Given this list of marker genes Eya2 (EYA transcriptional coactivator and phosphatase 2), Gdpd1 (NCBI Gene Id 66569), Plcb1, Ublcp1, Ephx2, Gdpd2, Ptpro, Dusp22, Epm2a, Plcb4, Pfkfb1, Tab1, Pde4b (phosphodiesterase 4B, cAMP specific), Ppp4c, Smpdl3a, Pde1a, Cpped1, Anp32e, Plcxd3, B3gat3, Dusp9, Ppp2r1b, Ptprh, Tns1, Ppp1r3d, Fbp1, Dusp7, Plppr5 (NCBI Gene Id 75769), Ppm1k, Mtmr3, Ptpn18, Nt5dc3 (NCBI Gene Id 103466), Aptx, Itga1, Pld3, Ptp4a1, Plch1, Ppp1r17, Ptpra, Fra10ac1, Ppp1r1b, Dusp1, Tns3, Mtmr4, Ptpn1, Lpin1, Ppp2r2b, Ptprk, Nt5dc1, Synj1, Mtmr11, Apex1, Elfn1 (NCBI Gene Id 243312), Tescl, Cmya5, Ptprn2, Ppp3r1, Calm1, Ppp3cb, Acp7, Ptpn21, Plcz1, Tdp2, Ppm1l, Nt5c2, Minpp1, Inpp5a, Ppp1r14a, Enpp1, Pde6c, Inpp5e, Phactr3, Dusp12 (dual specificity phosphatase 12), Ppm1h, Mtmr6, Pde6g, Dmpk, Vrk3, Cdkn3, Ppp2r5b, Cdc25b, Arf1, Ssh1, Pfkfb2, Mtmr10, Tulp2, Arpp19, Ptpdc1, G6pc3, Styx-ps, Pde7a, Ptprj, Gdpd4, Pgp, Slc39a10, Plcl2, Plcb3, Ppp1r3c, Dusp6, Enpp3, Tigar, Car3, Ssh3, Mtm1, Gpcpd1, Dusp26 (NCBI Gene Id 66959), Gnas, Dusp18, Cnep1r1, Ptk2 (PTK2 protein tyrosine kinase 2), Igfbp2, Ppp1r27, Pde1c, Nt5c3b, Mtmr14, Ppp2r1a, Psph, Acp1, Dusp16, Ppp4r4, Ppp1r16a, Plppr2, Ppef2, Ptprc, Sbf1, Phospho2, Rcan3 (NCBI Gene Id 53902), Ptprg, Rngtt (RNA guanylyltransferase and 5'-phosphatase), Smpd4, Eya3, Plcl1, Inpp4a (inositol polyphosphate-4-phosphatase, type I), Cip2a, Dusp28, Pald1, Ppm1a, Pip4p2, Ptpn22, Dusp13a, Inpp1, Plce1, Pdgfra, Nt5c1b, Mtmr12, Pon1, Plcd3, Ppp2r5d, Pde10a, Smpdl3b, Nt5dc2, Arf4, Entpd3, Styx, Ppef1, Pde5a, Ptprd, G6pc1, Samhd1, Apex2, Plcd1, Sh3rf2, Ppp1r12b, Pde11a, Ccl5, Phlpp1, Hddc3, Hsp90ab1, Ptpn20, Dusp11, Sgpp1, Ppp1cc, Pld6, Sacm1l, Pudp, Ensa, Ppp1r14d, Alpl, Ctdspl, Ppp1r15a, Napepld, Plch2, Mgat5, Smpd5, Cabin1, Ppp1r3e, Ppp1cb, Acp4, Ppp1r3a, Acp5, Ctdp1, Noct, Sgpp2, Cdc14b, Pptc7, Cnp, Mtmr1, Ppp3ca, Pon3, Pde6b, Lck, Pde2a, Fan1, Ppp4r3c2, Pde3a, Ppp1r15b, Ptprq (NCBI Gene Id 237523), Fbp2, Tpte, Plcg1, Dusp8, Ptpn14, Mppe1, Gnb1, Pde7b, Bod1, Dusp4, Ywhab, Arl1, Plppr3, Ptpn23, Inpp4b, Ywhae, Tprn, Ppp1r1c, Ppp2r3d, Tns2 (tensin 2), Ptpn9, Ppm1f, Ptp4a3, Gnaq, Mtmr7, Ppp1r8, Inppl1, Lhpp, Ppp1ca, Nt5c3, Pld2, Pfkfb4, Tiprl (TIP41, TOR signalling pathway regulator-like (S. cerevisiae)), Dusp21, Pfkfb3, Pank4, Mdp1, Cdca2, Ctdsp2, Tesc, Ppp6c, Nt5c1a, Styxl2, Gde1, Ppp3r2, Dusp10, Ppm1j, Pabir2, Dusp19, Pld4, Prune1 (NCBI Gene Id 77902), Ppp1r1a, Ptprz1, Cry2, Enpp6, Enpp7, Plppr1, Hdhd2, Sirpa, Enoph1, Nt5c, Nt5e, Ppm1g, Ppp4r2, Ppp2r2a, Ppp1ccb, Htt, Impa2, Fig4, Nanp, Ctdsp1, Pip4p1, Ppp2cb, Ptpn3, Tdp1, Plcd4, Ccr1l1, Ambra1, Ppp2r3a (NCBI Gene Id 319351), Igfbp3, Ptpn11, Ppp1r9b, Mtmr2, Rcan2, Ocrl, Rcan1, Hras, Ptpre, Ppa2, Plpp2, Timm50, Alppl2, Ppp6r3, Ppp1r12c, Pgam5, Acp6, Ptpn5 (protein tyrosine phosphatase, non-receptor type 5), Ppp1r26, Nt5m, Plpp1, Ptp4a2, Ssu72, Eya4, Ppp1r14b, Ptprt, Smpd3, Acp2, Ppp4r3c1, Ubash3b, Armt1, Ppp6r1, Smtnl1, Pxylp1, Ptprv, Rpap2, Enpp2, Pde1b, Ppp2r2d, Stx4a, Dnajc6, Ppp1r12a, Ctdspl2, Igbp1b, Pld1, Ppp5c, Ppm1n, Phactr4, Dusp14 (dual specificity phosphatase 14), Csnk2a1, Inpp5k, Ctdnep1, Ppp1r3b, Bpnt2, Ppp2ca, G6pc2, Tmem225, Ppp4r1 (NCBI Gene Id 70351), Ptpmt1, Ppp1r14bl, Nsmaf, Sbf2, Mpped2, Pde4a, Plcxd2, Pde4c, Ptpn6, Ppp1r16b (protein phosphatase 1, regulatory subunit 16B), Inpp5f, Plcg2, Eya1, Ptpru, Cd33, Gtf2f1, Pnkp, Pdp1, Lmtk2, Dusp5, Ppp1r2, Plpp7, Pabir1, Acp3, Ssh2, Phlpp2, Pde8b, Eed, Ptpn7, Ppm1d, Ptpn2, Dusp23, Ptprs (NCBI Gene Id 19280), Dusp2, Pde6h, Dusp3, Ptpn4 (protein tyrosine phosphatase, non-receptor type 4), Bpnt1, Ppp2r5a, Hmox1, Pde4d, Pde6a, 2810408A11Rik, Ppp3cc, Akp3, Ppm1e, Plcb2, Ppp4r3b, Ppp4r3a, Hsp90b1, Gna12, Igbp1, Pde6d, Inpp5b, Bckdk, Phactr1, Ppp2r5e, Pde9a, Ppp1r37, Ptprf, Cdc25a, Ptprb, Atp1a1, Plpp3, Dusp15, Ppp1r10, Ppp2r2c, Ppp1r14c, Pten (NCBI Gene Id 70161), Plpp4, Ptprr, Bmp2k, Gna11, Elfn2, Smpd1, Plcxd1, Pde8a, Ccr1 (NCBI Gene Id 12768), Wbp11, Gpld1, Synj2, Lpin3, Lpin2, Ppp1r35, Phpt1, Plpp6, Gdpd3, Pde3b, Ppp6r2, Ppp2r5c (protein phosphatase 2, regulatory subunit B', gamma), Hddc2, Inpp5j, Ppp1r7, Ptn, Ppp1r11, Nit1, Dusp13b, Impa1 (inositol (myo)-1(or 4)-monophosphatase 1), Bmp2, Ficd, Pp2d1, Pdxp, Ptpn12, Smpd2, Uri1, Gdpd5, Alpi, Ppm1m, Ptpn13, Pdp2, Ppm1b, Adprm, Ptprn, Plppr4, Inpp5d, Dusp29, Plpp5, Ptprm, Styxl1, Phospho1, Myoz1, Ptpa, Ppp1r36, Calm3, Cdc25c (cell division cycle 25C), Ilkap, Cdc14a, Calm2, here is a description of the gene set: Catalysis of the reaction: RPO-R' + H2O = RPOOH + R'H. This reaction is the hydrolysis of any phosphoric ester bond, any ester formed from orthophosphoric acid, O=P(OH)3. studied in species Mus musculus Mouse Gene Set: GOMF_PHOSPHORIC_ESTER_HYDROLASE_ACTIVITY